Given this list of marker genes KRT12, ANKZF1, KLHL21, RARS1, IRS2, GJB2, EPO, ACKR2, BMP15, FBXW2, H1-4, FGD1, FCRLA, FCER2, FUT1, CELF1, ADAMTS1, CRP, COPE, CENPA, CISD1, ODF1, GABARAPL1, MARK4, FZD9, CCKBR, KCNE1, MYO1C, ARX, CFI, TENM1, IL1A, DMRTB1, LRP6, DUT, MYO10, RP9, FAM110A, PBX3, CNN2, RFK, NAA11, HTR3A, GJA4, ARFGAP3, G6PC2, CNP, COL8A1, APBA2, ARG1, PMM2, LTBP3, REEP6, IRF8, IGFBP6, ATP6V1B2, AQP2, MEOX1, RAX, HPGD, NSMCE1, ASF1B, LGI4, MRPL3, RYK, KRT6A, DNAJA1, GZMM, PCBD2, DNAJB1, NTN1, RAD52, NPM3, ADAM9, CBFA2T3, CYP4A22, AFF4, ECE1, CALCB, IL9, CLCNKB, COPS7A, IRF2BP1, KLF12 (KLF transcription factor 12), GSTT2, PLAC9, MBL2, MYCBP, CDKN1B, CYBB, AIRE, MPHOSPH9, LCT, CREBBP, CD40LG, DKK3, CCR6, GSPT2, CYP2A6, GPSM3, CD14, GPR37 (G protein-coupled receptor 37), MSI1, PHKG1, ARPC5L (NCBI Gene Id 81873), NLRX1, NRG3, BMP2K, PKP1, ATN1, AMBN, PRPF39, EMP3, ARF5, MYH14, NDUFB10, RAD23A, DDX52, DNAJA3, POU3F3, PCDH7, IL5, CIDEC, HSPG2, NR0B2, MYT1, GATA1, KIF3C, MFNG, RBFOX2, CLGN, IGF1, PDGFRB, BMP8A, DNAJA2, GABRB1, NPPC, CALCRL, NKAIN1, GSC, NHSL2, METTL18, PHLDA2, MCUR1, CLN3, IQGAP3, BLK, EPHB2 (EPH receptor B2), REXO5, ACO1, PROS1, PENK, MIF, NOP58, PRR15, IRAG1, OPRD1 (opioid receptor delta 1), RUNDC3A, BARX1, LRP5, EIF2B4, MC5R, AMOT, PREB, EFNA3, LACTB2, HAX1, LRBA, CDH13, KDELR3, HPN, LCAT, P3H3, IFNB1, DAB1, FRAT2, MATN3, OR6A2, BPIFA2, RENBP, POLR2F, MEST, ACVRL1, GRIA3, EIF3B, GJA1, CRISP3, GBA2, IGFBPL1, MRPL27, PROP1, FABP9, IDO1, IL4 (NCBI Gene Id 3565), DHH, ATP6AP1, GPN3, FMC1, GP9, here is a description of the gene set: from publication Agarwal P, Raghavan A, Nandiwada SL, Curtsinger JM, Bohjanen PR, Mueller DL, Mescher MF (PMID 19592655) Differentiation of naive CD8 T cells into cytotoxic effector cells requires three distinct signals- antigen (signal 1), costimulation -B7-1 (signal 2) and cytokine, either interleukin-12 or interferon-a/b (signal 3). Interaction of naive CD8 T cells with antigen and B7-1 programs cell division and proliferation whereas the presence of cytokines- IL-12 or IFNa/b promote survival, differentiation and memory establishment. In the absence of signal 3, the cells interacting with antigen/B7-1 undergo tolerance induction. The objective of this study was to elucidate the mechanisms how the provision of signal 3 promotes differentiation and averts tolerance induction in CD8 T cells. Trichostatin A is a pharmacological agent that inhibits histone deacetylase activity, hence regulating chromatin structure and gene expression and differentiation in many cell types. Gene signature profiles of IL-12, IFNa/b and trichostatin A stimulated cells were compared to elucidate the molecular mechanisms of gene regulation. Oligonucleotide microarray analysis is carried out to determine the extent and molecular nature of the CD8 T cell differentiation program induced by IL-12 or IFNa/b in concert with antigen and B7-1 signal. species: Homo sapiens Human Gene Set: GSE15930_STIM_VS_STIM_AND_TRICHOSTATINA_24H_CD8_T_CELL_UP Genes up-regulated in comparison of unstimulated CD8 T cells at 24 h versus CD8 T cells at 24 h after treatment with trichostatin A (TSA).